The following is a description of a gene set: Extra-nuclear estrogen signaling Mouse Gene Set: REACTOME_EXTRA_NUCLEAR_ESTROGEN_SIGNALING studied in species Mus musculus, and this is the list of marker genes: Hras, Gng10, Foxo3, Esr1, Mapk1, Gng11, Pik3r3, Gng2, Mmp9, Epgn, Gng12, Gnb3 (guanine nucleotide binding protein (G protein), beta 3), Gnai3, Mmp7, Pik3ca, Gnai2, Ereg, Igf1r, Areg, Gnat3, Pdpk1, Uhmk1, Btc, Gngt1, Egf, Nos3, Calm1, Gng5, Hbegf, Esr2, Cdkn1b, Pik3r1, Ptk2, Gnb1, Src, Gng7, Shc1, Zdhhc7, Gnai1, Akt3, Gngt2, Cav2, Calm3, Gng3, Calm2, Gnb5, Mmp2, Mmp3, Akt2, Gng8, Pik3r2, Strn, Gnb4, Xpo1, S1pr3, Sphk1, Prkcz, Hsp90aa1, Prmt1, Gng4, Zdhhc21, Tgfa, Gnb2, Creb1, Akt1, Gng13, Egfr, Hspb1, Cav1, Kras